The following is a description of a gene set: Human Gene Set: GSE10240_IL22_VS_IL22_AND_IL17_STIM_PRIMARY_BRONCHIAL_EPITHELIAL_CELLS_DN Genes down-regulated in primary bronchial epithelial cells stimulated with: IL22 versus IL17A and IL22. studied in species Homo sapiens from publication Aujla SJ, Chan YR, Zheng M, Fei M, Askew DJ, Pociask DA, Reinhart TA, McAllister F, Edeal J, Gaus K, Husain S, Kreindler JL, Dubin PJ, Pilewski JM, Myerburg MM, Mason CA, Iwakura Y, Kolls JK (PMID 18264110) Primary HBE cells were stimulated with IL-22 and IL-17, and gene expression was studied using an Affymetrix platform microarray, in order to investigate which genes may be upregulated or downregulated in response to these cytokines. Of particular interest was the host defense genes such as antimicrobial peptides, which have been shown to be upregulated by IL-22 and IL-17 in skin keratinocytes., and this is the list of marker genes: GJA4, KDF1, RHOQ (ras homolog family member Q), EZH1, SLC25A53, ZYX, DTX3, CARS1, RXRB, CTNND2, KAT2A, IRF7, LZTS2, PHC1, SDR39U1, PARP3, SSH2, EVL (Enah/Vasp-like), RESP18, COBLL1, BCL2L11, OGA, ULK4, PARP1, RTP4, MEX3A, ESR2, PHF12, CDK19, TREX1, ARHGEF10, RPS27, BAIAP2L1, CLCN3, CYB561A3, GPR137, RMI2, FAM174B, MACROH2A1, GIMAP6, FNDC7, RMND5B, RC3H1, LRRC75A, MOB3A, IER5, CASKIN2, PRSS53, MATCAP1, MFNG, TP53BP1, HOXB13, CIMAP1A, OSBPL5, ARHGAP4, SLC22A9, SLC41A3, PNRC1, SEZ6L (seizure related 6 homolog like), SNN, TUT7, IL18R1, TSC22D1, SF3B3, TRAF4, ADGRG3, DLG4, C5orf46, PPP1R16B, ENG, RASGRP3, ITPKB, RNF123, GPAA1, TRPC7, TP53INP1, PRR36, OTOA, MED13L, MAP3K11, ZNF608, MYO1C, GLTP, MCL1, PAQR5, LCA5L, CD79A, HBEGF, ANKS1A, HES1, TAMALIN, EEF2K, SORBS1, IRF2BP1, UBP1, CSNK1G2, RNF157, AKAP13, BLK, CD38, TRIM54, HOXC6, UTRN, MEA1, SLC35D3, SLC26A11, SMAP2, PROP1, MAFK, FCHO1, SLFN13, PAG1, SLC14A1, CRIP1, ELOVL6, ZNF428, TEF, MNT, CARD11, CAMK1D, LDB1, ELK3, PHKG1, ATP13A2, AQP9, TET1, SMCO2, ITIH5, WIPI1, ATP5MC2 (NCBI Gene Id 517), LTB, CCR9, HELZ2, IGF2BP1, MTA3, JMJD7-PLA2G4B (NCBI Gene Id 8681), PDE4B, OSBPL1A, WDR6, HSF2, IGLL1, BANK1, DMRT1, ADAP2, BMP2K, KRT24, IPCEF1, LMNTD2, LRP10, TBX15, NDST1, CHD3, DKKL1, APCDD1, ABLIM1, RIC8A, ELK4, C2orf88, ITGA4, BHMT2, PLEKHA2, SMARCA4, METAP1D, EPHA2, CRACDL, MGAT1, ANKRD54, ZFP1, FYN, TACR2, SLC43A2, COL19A1, BTRC, EN1, RNF144A, PTGDR2, URI1, PEAK1, CD47, PIP4K2A, PRKD2, COX6A2, SLC15A3, HLA-DQA1, LYNX1, CBX2, RAC2, CNP, MVK, HLA-DRB1, DYNC2H1, TRAF3IP2, MEF2C, SRRM2, PPP1R18, GALT, CPSF7, PPP1R15A, IGSF8, TBC1D16